The following is a description of a gene set: An abnormality of the hip joint. studied in species Homo sapiens Abnormal hip joint morphology Human Gene Set: HP_ABNORMAL_HIP_JOINT_MORPHOLOGY, and this is the list of marker genes: PTRH2, RFWD3, SMC3, GARS1, MYH3, COL2A1, MBTPS2, SLC2A10, OCRL, FIG4, DISP1, BMP4, EXT2, LMNB2, KMT2D, SCYL2, HACD1, DYNLT2B, HSPG2, PLCH1, HNRNPH1, PTCH1, WDR35, RPS15A, RMRP (NCBI Gene Id 6023), PIGL, ERCC4, APC2, KLHL41, GPC3, NKX3-2 (NCBI Gene Id 579), WNT5A, XRCC2, GORAB, DHODH, COL9A3 (collagen type IX alpha 3 chain), COL25A1, ABCC6, LMOD3 (leiomodin 3), FAT4, DNAJC21, ITGA7, COL6A2, BRD4, FANCI, MYO9A, CDON, IFT52, PTPN22, CD96, RUNX2, FHL1, GPC4, GJA1 (gap junction protein alpha 1), CHAT, ATR, PYCR1, FANCE, B3GAT3, EXTL3, GPHN, SOX9, ECEL1, THRA (NCBI Gene Id 7067), CENPJ (centromere protein J), NGLY1, POLR1A, IPO8, ALG9, SMO, HOXA11, ARSK, ATP6V1E1, SLC5A7, FBN1, FANCD2, VAC14 (VAC14 component of PIKFYVE complex), CANT1, AHDC1, UBE2T, EIF4A3 (NCBI Gene Id 9775), DPYSL5, AFF3, NSD1, RAD51C, TCTN3, EYA1, FILIP1, COL12A1, XYLT1, COL1A2, CCN2, FKRP, CFL2, POMT1, ALDH18A1, USP9X, FUT8, BGN, FBN2, LONP1, THOC2, KDM6A (lysine demethylase 6A), C12orf57, NFIX, ZNF469, PI4KA, DHCR7, CPLX1, MYO18B, MMP2, EXOSC3, KIF22, COX8A, FANCG, UFSP2, GNPAT, WDR19, LARGE1, MUSK, ERI1, ABCC9, IARS2 (NCBI Gene Id 55699), MASP1, VAMP1 (NCBI Gene Id 6843), FANCB, BICRA, RNU4ATAC, CRTAP, STIL, PTPN2, SPEG, PAM16, NAA10, SLC35A3, SLC35A2, TMEM67, SIL1, HYAL1, RECQL4, NIPBL, FANCF, SMOC1, FKBP10, HDAC8, ANKRD55, STAG2, MAP3K20, AKT1, ZNF407, NSDHL (NCBI Gene Id 50814), AP4M1, LTBP1, SNAP25, PLOD1, TOR1A, KAT6B, DDR2, COMP, FGFR3, GLI3, COLEC10, SERPINF1, YWHAE, ATAD1, IL6ST, AP4B1, TNNT3, COL5A1, COG1, GNB2, TRAPPC12, UBE3B, SLC6A5, RYR1, MAD2L2 (NCBI Gene Id 10459), CCDC47, GUSB, MYL2, KIAA0586, HK1, LRP4, NRCAM, CLTCL1, AGRN, MYH8, FGFRL1, ZMPSTE24, NFATC2, COLEC11, RAB33B, LRP1, TBX4, EBF3, RAD51 (NCBI Gene Id 5888), TBX15, SMC1A, CRIPTO, MCTP2, CHST3, GMPPB, GLRB, PIEZO2, SHROOM4, TTN, INPPL1, TAF6, EVC, KIAA0753, SEC31A, PALB2, SIX3, CUL7, AP4E1, MYL11, TPM3, MACF1, BRCA1, CSPP1 (NCBI Gene Id 79848), COL5A2, UBA1, PAFAH1B1, ERLIN2, CEP120, DYNC2I1, GET4, ZC4H2, NEPRO, CHRNG, HACE1 (HECT domain and ankyrin repeat containing E3 ubiquitin protein ligase 1), OSTM1, NANS (N-acetylneuraminate synthase), GPX4, GNPNAT1, PHLDB1, IL2RB, PIGY, LAMA5, ATP6V1A, NODAL (NCBI Gene Id 8114), OSGEP, TBCD, CCN6, STAT4, IL2RA, AP3B1, DYNC2H1, GNPTAB, SYT2, ARNT2, OBSL1, P4HTM, LYSET, SLC18A3, SLC10A7, FANCL, MAP3K7, RINT1, TPM2, ACTA1, CEP85L (NCBI Gene Id 387119), BIN1, NSD2, COL6A3, PTH1R, AP4S1, SPARC, GSC, CCDC8, HDAC4, PYCR2 (pyrroline-5-carboxylate reductase 2), ERCC8, RBM8A, FGFR1, GDF5, EIF2AK3, EVC2, SCN4A, POMT2, F8, EBP, FLNB, FLNA, TGFB2, EXT1, ZIC2, FLI1, ERCC1, ZBTB20, SLC12A2, SLC6A9, COL27A1, CTBP1, SMAD3, EFEMP2, ROR2, PPP2R5D, TNNT1, SLX4, SLC35D1, AFF4, FANCA, LMNA, GLRA1, B3GALT6, SLC25A1, MYL1, TIMM22, HS2ST1, TRPV4, RYR3, AARS1, DYM, ZIC3, TGFBR2, PNPT1, ATP6V0A2, PUF60, IFIH1, COL6A1, DLL1, CD247, MATN3, COL1A1, FZD2, CTCF, SMARCAL1, ADAMTS2, COL13A1, BICD2, RAD21, GEMIN4, CSGALNACT1, SF3B4, HPRT1, CHD4, UBA2, TFE3, SELENON, CHRM3 (cholinergic receptor muscarinic 3), FGF8, TRIP11, TRIM8, BRCA2, GAS1, GLI2, FBLN5, EXOC6B, SNRPB, ATP7A, FBLN1, UNC80, PORCN, ERGIC1, NEB, SLC26A2, MKKS, BRIP1, SHH, AEBP1, FANCM, DSTYK, DVL1, ARSB, VPS33A, TELO2, WNT7A, POLR3B, RAB23, FANCC, COL10A1, NALCN, FOXH1, ENPP1, PIGA, APC, DVL3, KANSL1, CLCN3, ADAMTSL2 (ADAMTS like 2), SIX1, LETM1, GLB1, LGI4, ELN, COL3A1, FGFR2, PPIB, TONSL, TGIF1